Given this list of marker genes TRBV6-4, CXCR5, OSBPL10, RFLNB, EIF4B, SLC45A3, IL1R2, NIBAN3, BLK, CNR2, SCARNA6, here is a description of the gene set: To better understand how innate immune responses to vaccination can lead to lasting protective immunity, we used a systems approach to define immune signatures in humans over 1 wk following MRKAd5/HIV vaccination that predicted subsequent HIV-specific T-cell responses. Within 24 h, striking increases in peripheral blood mononuclear cell gene expression associated with inflammation, IFN response, and myeloid cell trafficking occurred, and lymphocyte-specific transcripts decreased. These alterations were corroborated by marked serum inflammatory cytokine elevations and egress of circulating lymphocytes. Responses of vaccinees with preexisting adenovirus serotype 5 (Ad5) neutralizing antibodies were strongly attenuated, suggesting that enhanced HIV acquisition in Ad5-seropositive subgroups in the Step Study may relate to the lack of appropriate innate activation rather than to increased systemic immune activation. Importantly, patterns of chemoattractant cytokine responses at 24 h and alterations in 209 peripheral blood mononuclear cell transcripts at 72 h were predictive of subsequent induction and magnitude of HIV-specific CD8(+) T-cell responses. This systems approach provides a framework to compare innate responses induced by vectors, as shown here by contrasting the more rapid, robust response to MRKAd5/HIV with that to yellow fever vaccine. When applied iteratively, the findings may permit selection of HIV vaccine candidates eliciting innate immune response profiles more likely to drive HIV protective immunity. Genes down-regulated in peripheral blood mononuclear cell 3d vs 0d in adults (20-50) after exposure to MRKAd5 HIV-1 gag/pol/nef, time point 3D. Comment: Table includes specific cell types species: Homo sapiens from publication Zak DE, Andersen-Nissen E, Peterson ER, Sato A, Hamilton MK, Borgerding J, Krishnamurty AT, Chang JT, Adams DJ, Hensley TR, Salter AI, Morgan CA, Duerr AC, De Rosa SC, Aderem A, McElrath MJ (PMID 23151505) Human Gene Set: ZAK_PBMC_MRKAD5_HIV_1_GAG_POL_NEF_AGE_20_50YO_3DY_DN